The following is a description of a gene set: Any process that activates or increases the frequency, rate or extent of fatty acid transport. Mouse Gene Set: GOBP_POSITIVE_REGULATION_OF_FATTY_ACID_TRANSPORT studied in species Mus musculus, and this is the list of marker genes: Tnfrsf11a, Pla2g3, Il1a, Cyp4a32, Tnfsf11, Cyp4a10, Sstr4, Oxt, Fabp3, Pla2g10, Ntsr1, Mapk9, Il1b, Mif, P2ry2, Pla2r1, Pla2g4a, Hrh3, Acsl6, Erfe, Acsl5, Map2k6, P2rx7, Avpr1b, Pla2g6, Edn1, Cyp4a31, Ptges, Acsl1